Given this list of marker genes TGIF2, SENP2, RBM34, PANK3, MAPK1, BAZ2A, SRSF6, PTAR1, SLK, SRD5A2, AKAP9, TP53TG3D, C17orf49, CXCL3, SLC12A2, ARF4, KBTBD2, LRP1B, NAA30, ZNF302, MMS19, KPNA1, BRMS1L, TMEM248, MAP1B, CHMP4B, FNDC5, MEAF6 (MYST/Esa1 associated factor 6), COG5, PGR, ZNF398, UNC13C, SULF1, INVS, SIRT3, LRP2, STAG2, ERC2, CASP1, GSTZ1, MOSMO, LGALSL, ZFHX3 (zinc finger homeobox 3), CLASP1, NSD1, MSMP, MBOAT2, USP9X, SLC25A4, ZNF587, TGOLN2, SRRM4, ANKRD30B, COX11, GSK3B, TICAM2, ABCA1, GIT2, EXOC2 (exocyst complex component 2), TP53TG3B, SCN5A, PRKACB, GOT2, RCSD1, BTLA, HMGCS1 (3-hydroxy-3-methylglutaryl-CoA synthase 1), ZFAND3 (zinc finger AN1-type containing 3), SLC43A2, SLC6A13, THEM4, ABTB3, TMEM33 (transmembrane protein 33), PBOV1, TAOK1, HSPA12A, NAA15, BTBD1, PROX1, NTRK2, LGSN, RC3H1, KCNC2, P2RY1, MAP3K19, DIO3, RGS22, TRDN, SNX12, NOX4, PDE12, RNF145, C1QA, CAPZA1, GALNT1, MBNL1, IRS1, IL17RD, SPOPL, SORL1, SEMA5A, TBPL1, SMARCA5, PARP16 (NCBI Gene Id 54956), UHMK1, SETD9, LEPROTL1, MECOM, GDNF, RNF2, DPP4, STX6, PER1, PHC3, PRDM11, SHOC2, ARB2A, DCUN1D1, RASSF6 (Ras association domain family member 6), SPDYE3, FLRT3, PPIE, ZBTB1, BSDC1, TAB2, FAT4, HHIPL2, FBLN5, CDK13, ANKRD28, LYSMD3, C16orf87, NUP98, CMTM4, MTCL1, SEC31A, DLL1, JMJD4, ABHD2, GPR6, TMED7-TICAM2, RASEF, RAB8A, SCAMP3, KRTAP24-1, AAK1, VASP, SLC30A7, CCDC184, SMG7, PRR14L, VSTM4, HMG20A, ZBTB33, FRAT2, PPP1R2, TNPO1, CDKN1C, SLITRK1, ADSS2, HIPK1, SPOCK2, PPP6C, SIX4, HSCB, C2orf76, LRP12, RBFOX1, TXLNA, KIF12, SGIP1, KIAA1549L, BCL11B, OXR1, AICDA, TLK1, ESRRG, SLC13A1, SYT6, CNOT9, RUBCN, ZNF254, TET3, KCNJ13, ZFP36L2, TMPO, NVL, RABL3, ARL8B, PROSER1, C19orf12, NEXMIF, ST8SIA2, CCDC6, WAC, RBM25, CAPNS2, GNB1, DOLPP1, ESAM, SSTR1, PATJ, UBFD1, PSME4, SEMA3C, MALL, GPD1, ATG16L1, IL19, JPH1, SLC8A1, SOS2, MGST1, PLXDC2, PTAFR, ANKRD13C, RELN, NFATC2, LUC7L, CCDC141, ETV1, JADE2, SLC16A1, ZCCHC7, ZNF264, ARPC5L, RTN4RL1, CDK6, RNF213, VIRMA, IRS2, AGMAT, MLXIP, TAB3, SMYD5, FAM110D, GNAQ, RHNO1, SHTN1, MFN2, PYM1, TRIM33, KICS2, AGPAT4 (NCBI Gene Id 56895), SSR1, CSF1, CAMK2D, SREK1, MTF1, FRAS1, ARMC9, PXYLP1, SIMC1, ATRX, HSD17B8, ZBTB5, IGSF3, FGFBP1, FCMR, NMUR2, SHB, ITPK1, TSC22D1, TP53TG3, PCDH20, USP38, CD6, MBD1, UGGT1, NOMO3, TPR, GPR156, KSR1, SMPD3 (NCBI Gene Id 79756), CPD, DNM3, PRKAR2A, ERCC8, KDM2A, PITPNC1 (phosphatidylinositol transfer protein cytoplasmic 1), LPIN2, PWWP2A, SCP2, LMO4, PPIP5K1, CDS2, SMUG1, AMMECR1L, UNC5C, NAIP, MFSD4B, GHITM (NCBI Gene Id 27069), OPRK1, DUXA, C11orf97, PTBP3, STX17, USP30, ARHGEF12, ARPP21, PCGF3, KCNC4, MBTD1, HEY2, PGF, CTNNA3, SLC25A31, SSH1, COG6, NXT2, ATP2A2, DOCK11 (NCBI Gene Id 139818), TFAP2D, RBM20, TOMM22, TMEM30A, RNF180, MVB12B, PGAP3, CCDC191, VPS33A, ITGB8, RAVER1, ADORA3, ZNF81, SFTPB, ERRFI1, PPP1R8, KITLG, SNTB2, SDAD1, ZDHHC3, FIGN, KCNIP1 (potassium voltage-gated channel interacting protein 1), AP1G1 (NCBI Gene Id 164), CSTF1, BTAF1, ARHGAP26, PTHLH, MTMR3, ATP9A, CERT1, PRLR, GPR85, YWHAB, DMXL2, PPARGC1A, ICE2, EXOC6B, ZNF417, SORBS1, UBE4A, SMARCE1, AHCYL1, CIT, NCOA4, GAREM2, NMT1, SLC25A42, LGALS8, GCC2, ELOVL5, CDH11, STEAP4, ZNF112, ATP8A1, RFX7, NDUFA4, IRF4, GPR26, SCN2A, NFATC3, FBXO44, ST6GALNAC1, USP3, ZBTB39, JOSD2, UCHL1, SEPSECS, VGLL4, NEO1 (neogenin 1), here is a description of the gene set: from publication Chen Y, Wang X (PMID 31504780) Genes predicted to be targets of miRBase v22 microRNA hsa-miR-4291 in miRDB v6.0 with MirTarget v4 prediction scores > 80 (high confidence targets). Human Gene Set: MIR4291 species: Homo sapiens